The following is a description of a gene set: BACKGROUND: Females with the neurological disorder Rett syndrome are heterozygous for mutations in X-linked MECP2 that encodes methyl-CpG binding protein 2 (MeCP2) thought to act as a transcriptional repressor. To identify target genes for MeCP2 modulation, we studied global gene expression in single cell-derived wild-type and mutant MECP2 expressing fibroblast clones with four common mutations (R106W, R306C, 705delG, 1155del32) and in lymphoblastoid cell lines (LCLs) that included four mutant MeCP2 (T158M, 803delG, R168X and 1159del28) expressing, and five (1159del28, R106W, R255X, 803delG, 803delG) wild-type MeCP2 expressing lines. METHODS: Clonality and mutation status were verified by androgen receptor methylation assays for X-inactivation and by sequencing MECP2 transcripts. Expression studies were done with oligonucleotide microarrays (Affymetrix U95) and verified with real-time quantitative RT-PCR using Sybr Green. RESULTS: Expression of 49 transcripts was increased, and expression of 21 transcripts was decreased, in at least 3 of 4 mutant/wild-type fibroblast comparisons. Transcript levels of genes, determined by quantitative RT-PCR, were highly correlated with the microarray data. Therefore, multiple additional clones from two Rett individuals were tested by RT-PCR only. Striking expression differences were found in both mutant and wildtype MeCP2 expressing clones. Comparing expression profiles of lymphoblastoid cell lines yielded 16 differentially expressed genes. CONCLUSIONS: MeCP2 deficiency does not lead to global deregulation of gene expression. Either MeCP2's in vivo function does not involve widespread transcriptional repression, or its function is redundant in cell types that also express other methyl-CpG binding proteins. Our data suggest that clonal fibroblast strains may show substantial inter-strain variation, making them a difficult and unstable resource for genome-wide expression profiling studies. Human Gene Set: TRAYNOR_RETT_SYNDROM_DN from publication Traynor J, Agarwal P, Lazzeroni L, Francke U (PMID 12418965) studied in species Homo sapiens Genes down-regulated in primary fibroblasts from Rett syndrom patients who carry mutations inactivating MECP2., and this is the list of marker genes: ENPP1, PTPRF, BEX4, RUNX1, IGFBP5, ITGA6, SLC26A2, CRIP1, KLF5, SEL1L3, AMIGO2, GREM2, COMP, CHCHD10, INAFM2